Given this list of marker genes MTF2, DDX39A, CEP57, STMN1, SNRPA, RPA1, NDC80, NASP, CNOT9, SKP2, SRSF11, MCM6, BLM, USP1, LBR, TFDP1, CDC20, ILF3, CDK1, NCK1, PNN, NCAPD2, MCM2, TTF2, RPIA, DNMT1, MSH2, CDKN2C (cyclin dependent kinase inhibitor 2C), DEK, CDC7, EXOSC8, FOXM1, ASF1A, SH2D1A, TCERG1, RFC3, HMGN4, HMMR, SMC4, DNA2, RAD54L, TOPBP1, EZH2, SRSF10, MRE11, MCM5, MYBL2, RAD51AP1, KATNA1, UBE2S, CAD, AURKB, CENPA, RFC4, MCM4, here is a description of the gene set: Human Gene Set: PUJANA_BREAST_CANCER_WITH_BRCA1_MUTATED_UP from publication Pujana MA, Han JD, Starita LM, Stevens KN, Tewari M, Ahn JS, Rennert G, Moreno V, Kirchhoff T, Gold B, Assmann V, Elshamy WM, Rual JF, Levine D, Rozek LS, Gelman RS, Gunsalus KC, Greenberg RA, Sobhian B, Bertin N, Venkatesan K, Ayivi-Guedehoussou N, Solé X, Hernández P, Lázaro C, Nathanson KL, Weber BL, Cusick ME, Hill DE, Offit K, Livingston DM, Gruber SB, Parvin JD, Vidal M (PMID 17922014) The XPRSS-Int network genes up-regulated in breast tumors from patients with germline mutations in BRCA1 compared to those with the wild type allele. studied in species Homo sapiens Many cancer-associated genes remain to be identified to clarify the underlying molecular mechanisms of cancer susceptibility and progression. Better understanding is also required of how mutations in cancer genes affect their products in the context of complex cellular networks. Here we have used a network modeling strategy to identify genes potentially associated with higher risk of breast cancer. Starting with four known genes encoding tumor suppressors of breast cancer, we combined gene expression profiling with functional genomic and proteomic (or 'omic') data from various species to generate a network containing genes linked by 866 potential functional associations. This network shows higher connectivity than expected by chance, suggesting that its components function in biologically related pathways. One of the components of the network is HMMR, encoding a centrosome subunit, for which we demonstrate previously unknown functional associations with the breast cancer-associated gene BRCA1. Two case-control studies of incident breast cancer indicate that the HMMR locus is associated with higher risk of breast cancer in humans. Our network modeling strategy should be useful for the discovery of additional cancer-associated genes.